The following is a description of a gene set: studied in species Homo sapiens A type of hearing loss resulting from a combination of conductive hearing impairment and sensorineural hearing impairment. Mixed hearing impairment Human Gene Set: HP_MIXED_HEARING_IMPAIRMENT, and this is the list of marker genes: POU3F4, MAP3K7, GDF6, EYA1, SIX5, CDH11, KMT2D, AMMECR1 (AMMECR nuclear protein 1), GJB6, DVL1, FGF10, FAM20C, FGFR2, FLNA, FLNB, ENPP1, GJB2, ABCC6, CDK5RAP2, PAX1, FBXW7, CHD7, AFF4, MAN2B1, GJA1, ELMOD3, RECQL4, IGBP1, RPS28, SIX1, ROBO1, HOXA2, FGFR3, PORCN, FKBP14, ARSL, COL11A2, B3GALT6, ANKH, SGMS2